Given this list of marker genes Rps2, H2ac6, Brpf3, Mbd3, H2ac10, Smarcc1, Jade2, H2bc14, Kdm7a, H2bc22, Pax3, Suv39h1, H2bc3, Carm1, H2ac22, Brms1, H2ac7, Ing4, H2ac24, Kat6b, H2ac19, H2bc12, H2ac20, H4c6, H2bc13, H3c15, Ash2l, H4c8, Kansl2, H2ac13, H2ac8, H2ac25 (H2A clustered histone 25), H3c11, Rbbp7, H3c8, H2bc8, H2ac15, Ccnd1, Kmt5b, Arid5b, Cdk4, H2ac11, H2bc11 (H2B clustered histone 11), Rela, H2ac1, Padi4, H3c1, H4c17, H2bc7, Kmt5c, Smarcb1, H3c13, Phf8, H4c9, H4c3, H2ac12, Prdm16, H4c2, Kmt2b, Ezh2, Kdm4c, H2bc27 (NCBI Gene Id 78303), Msl2, Prmt5, H4c14, Phf20, Arid4b, Prmt3, H2ac23, H3c6, Sap30l, Setd1a, Smarcc2, Smarca2, Setd7, Padi6, Setd6 (NCBI Gene Id 66083), Smarcd2, Mta1, Sap30 (sin3 associated polypeptide), Smyd3, Ncoa1, Actl6b, Kdm1b, Prdm9, Rbbp4, Smarca4, H3c7, Kat7, Ehmt1, Kdm4d, Dot1l, Nfkb2, Jade3, Kdm6b, Mta2, H3c2, H3c10, H2bc1, H4c18, H4c12, Arid1a, Kdm6a, Phf2, Suds3, H3c3, H4c1, H3c4, Hcfc1, Kdm1a, H4c4, Brpf1, H2bc9, Kansl1, Kdm2b, H2ac4, H4c11, Brwd1, Smarcd1, Msl3, Nfkb1, H2bc15, here is a description of the gene set: Reactome Pathway: Chromatin modifying enzymes This event has been computationally inferred from an event that has been demonstrated in another species.<p>The inference is based on the homology mapping from PANTHER. Briefly, reactions for which all involved PhysicalEntities (in input, output and catalyst) have a mapped orthologue/paralogue (for complexes at least 75% of components must have a mapping) are inferred to the other species. studied in species Mus musculus part of: Chromatin organization electronically inferred by orthology from the curated human pathway